The following is a description of a gene set: studied in species Homo sapiens A process which results in the assembly, arrangement of constituent parts, or disassembly of an actomyosin contractile ring. Human Gene Set: GOBP_ACTOMYOSIN_CONTRACTILE_RING_ORGANIZATION, and this is the list of marker genes: IQGAP1, ANLN, RACGAP1, IQGAP2, ECT2, VPS4A (vacuolar protein sorting 4 homolog A), RTKN, PDCD6IP, IQGAP3, PLEC